The following is a description of a gene set: Genes up-regulated in comparison of macrophages exposed to 5 worms/well B. malayi versus macrophages exposed to M. tuberculosis. species: Homo sapiens Monocyte-derived dendritic cells (DC) and macrophages (MΦ) generated in vitro from the same individual blood donors were exposed to five different pathogens, and gene expression profiles were assessed by microarray analysis. Responses to Mycobacterium tuberculosis and to phylogenetically distinct protozoan (Leishmania major, L. donovani, Toxoplasma gondii) and helminth (Brugia malayi) parasites were examined, each of which produces chronic infections in humans yet vary considerably in the nature of the immune responses they trigger. from publication Chaussabel D, Semnani RT, McDowell MA, Sacks D, Sher A, Nutman TB (PMID 12663451) Human Gene Set: GSE360_LOW_DOSE_B_MALAYI_VS_M_TUBERCULOSIS_MAC_UP, and this is the list of marker genes: VPS72, PECAM1, SLC6A8, GGA3 (NCBI Gene Id 23163), ZNHIT1 (zinc finger HIT-type containing 1), SSTR2, PRPF8, MEF2C, PLCG2, IFNA5, MYO1C, CRABP2, ARF5, DHX38, MX1, SDC1 (syndecan 1), CENPA, SPRED2 (sprouty related EVH1 domain containing 2), HNRNPAB, CTBP2, UPF3A, BRD1, NFYA, TRAP1, MYBPC2, FIG4, CLASP1, ALDH1B1, SHC1, CCR7, KRTAP26-1, SIAH1, PPP1R3D, ADGRL1, ENOSF1, P2RX4, ACRV1, MICAL2, RNF4, TNR, RHEB (Ras homolog, mTORC1 binding), TOMM34, SMYD5, SEMA5A, CDA, BSN, SLC7A5, TBC1D2B, PYGB, PFKFB1, TPM1, FAM32A, CREB1, VAV1, ALPI, USP5, SGSM2, EEF1D, TRIB1, EEF1B2, FAM149A, LGMN, LPAR2, DEFB1 (NCBI Gene Id 1672), KCNA3, KIF13B, ABHD14A, CLSTN1, RARRES1, BCAR3, LILRB5, BCL2L1, ATXN2, SIRPB1, MAPKAPK5, NCOR2, SREBF2, APOH, NBL1, PLOD3, FGR, NUP188, FMO6P, MAPRE2, PRRG1, SYNM, CDK4, NDUFV1 (NADH:ubiquinone oxidoreductase core subunit V1), GARS1, CRYBB1, MISP, MAGED1, TCF3, NAP1L4, MLF2, BRD3, HLA-DPA1 (major histocompatibility complex, class II, DP alpha 1), LIPE, ATP2B3, POLDIP3 (NCBI Gene Id 84271), HIC2, SYN3, RBM4B, SOX2, TDRD3 (NCBI Gene Id 81550), FARSA, MRTFA, BECN1, SPINK2, PHF1, NTNG1, ASS1, HRG, SEMA7A, DUSP3, LINC00847, TMSB4Y, MAPK8, RPS6KB2, VPS39, ADO (2-aminoethanethiol dioxygenase), ORC4, ADD1, CD1E, TEAD3, FCN1 (ficolin 1), HDAC2, DUS4L, LTA4H, DTNB, E2F4, CALM2, PPWD1, PSME4, PSG1, CYB5R1, GLB1, C6orf120, CDIPT, C1orf216, LPIN1, GFUS, KLF12, GPRIN2, LY86, ITGB5, NUPR1, RASSF1, SF3B2, ENTPD6, DIDO1, DCTN3 (NCBI Gene Id 11258), EMP3, ARTN, TFF3, PGC, CDK11A, SMPD1, SPECC1L, CLN3, PMS2P3, CDK10, ALDH3A2, MOAP1, NDRG2, PCCA, KDM4B, VAT1, PRCC (proline rich mitotic checkpoint control factor), NUTF2 (NCBI Gene Id 10204), ITGA3, FCGR2B, SLC13A3, PCDHB11, PPBPP2, MAGEB2, RAB4A (RAB4A, member RAS oncogene family), PLEKHM2 (pleckstrin homology and RUN domain containing M2), ISL1, ITGB1BP1, PACS2, TBX19, SERPINB6, ARL2BP (NCBI Gene Id 23568), RPS6KA1, CD83, PCCB, TARBP1, LAMB2, MAK16, GPR39 (G protein-coupled receptor 39), TACC1, IGF1R, UBTF, SERINC5, LILRA2, ADCYAP1R1, AP2S1, CDC25B